Given this list of marker genes Gfi1, Jak1, Scml4, Utrn, Wnk1, Bach2, Wipf1, C230085N15Rik, Lef1, Abtb2, Cpe, Rcbtb2, Stk10, Tespa1, Prag1, Tgfbr2, Ptger3, Lrch1, Foxp1, Cdk17, Bcl2, Trim34a, Peli1, Ankrd44, Clec2d, Ms4a4b, St8sia1, Ptprc, Syne2, Ms4a6c, Ptk2b, Dipk1a, E430014B02Rik, Satb1, Bcl11b, Cmah, A630081D01Rik, Rapgef6, Nipbl, Nrip1, Lpar6, Dph5, Ptbp3, here is a description of the gene set: from publication Zheng Y, Josefowicz SZ, Kas A, Chu TT, Gavin MA, Rudensky AY (PMID 17237761) Mouse Gene Set: ZHENG_FOXP3_TARGETS_IN_T_LYMPHOCYTE_DN Genes with promoters bound by FOXP3 and which are down-regulated only in mature (peripheral blood) regulatory CD4+ T lymphocytes. Transcription factor Foxp3 (forkhead box P3), restricted in its expression to a specialized regulatory CD4+ T-cell subset (T(R)) with a dedicated suppressor function, controls T(R) lineage development. In humans and mice, Foxp3 deficiency results in a paucity of T(R) cells and a fatal breach in immunological tolerance, causing highly aggressive multi-organ autoimmune pathology. Here, through genome-wide analysis combining chromatin immunoprecipitation with mouse genome tiling array profiling, we identify Foxp3 binding regions for approximately genes and for an intergenically encoded microRNA. We find that a large number of Foxp3-bound genes are up- or downregulated in Foxp3+ T cells, suggesting that Foxp3 acts as both a transcriptional activator and repressor. Foxp3-mediated regulation unique to the thymus affects, among others, genes encoding nuclear factors that control gene expression and chromatin remodelling. In contrast, Foxp3 target genes shared by the thymic and peripheral T(R) cells encode primarily plasma membrane proteins, as well as cell signalling proteins. Together, our studies suggest that distinct transcriptional sub-programmes implemented by Foxp3 establish T(R) lineage during differentiation and its proliferative and functional competence in the periphery. studied in species Mus musculus